Given this list of marker genes RPS27A, CBL, UBB, PTK6, ARAP1, UBA52, DOK1, UBC, AKT1, here is a description of the gene set: part of: Signaling by PTK6 PTK6 enhances EGFR signaling by inhibiting EGFR down-regulation. PTK6 may also enhance signaling by other receptor tyrosine kinases (RTKs), such as IGF1R and ERBB3.<p>PTK6 affects AKT1 activation and targets negative regulator of RTKs, DOK1, for degradation. studied in species Homo sapiens Reactome Pathway: PTK6 Regulates RTKs and Their Effectors AKT1 and DOK1